The following is a description of a gene set: Genes down-regulated in SaOS-2 cells (osteosarcoma) upon knockdown of YY1 by RNAi. Human Gene Set: DE_YY1_TARGETS_DN species: Homo sapiens from publication de Nigris F, Rossiello R, Schiano C, Arra C, Williams-Ignarro S, Barbieri A, Lanza A, Balestrieri A, Giuliano MT, Ignarro LJ, Napoli C (PMID 18339860) We know that the Yin Yang 1 protein (YY1) overexpression is positively and strongly correlated with the degree of malignancy of bone tumors. Therefore, we questioned whether we could influence cell invasiveness by deleting YY1 in human osteosarcoma cells (SaOs-2), as tested in Matrigel-coated filters and metastasis implantation of such osteosarcoma cells in vivo, by serial analysis with nuclear magnetic resonance. Moreover, we focused our work on the chemokine receptor CXCR4 and its inhibition by T22 antibody, as well as on systemic (direct in vivo assay) and computer-assisted imaging of angiogenesis-related metastasis. Results showed that cell invasiveness and metastasis implantation by wild-type SaOs-2 cells, as evaluated by histology and immunohistochemistry, are associated with up-regulation of CXCR4 expression, which in turn was significantly reduced by T22. In addition, deletion of YY1 (siRNAYY1-SaOs-2) induced a significant decrease of cell invasion and metastasis growth. This phenomenon was associated with decreased vascular endothelial growth factor (VEGF)/angiogenesis and a complex rearrangement of the gene expression profile as evaluated by microarray analysis. In conclusion, YY1 and VEGF/CXCR4 seem to intervene in the pathogenesis of the malignant phenotype of osteosarcoma by acting on cell invasiveness and metastasis growth., and this is the list of marker genes: CD2AP, CYLD, INHBA, CDK1, HSP90B1, ENC1, CAPZA2, CDC27 (NCBI Gene Id 996), WDR1, SRSF9, RBL1, NBL1, TAGLN2, OSMR, PRKD3, EGFR, HIF1A, BARD1, ITGAV, PRKAA1, DNTTIP2, PAFAH1B1, STAG1, IFT57, PRKACB, HNRNPC, CCNG1, APC, USP16, ANGPT1, ITGA4, IL13, GSPT1, EPAS1, TGFB2 (transforming growth factor beta 2, NCBI Gene Id 7042), DST, PTP4A1, MACF1, CSNK1G3 (casein kinase 1 gamma 3), RBBP8, CCNE2, LPAR1, TACC1, TNFRSF11B, EGF, NUMA1, MET, ANXA1, EPHA3, PKN2, RB1, GDI2, NRP1, SOCS5, RASSF3, HIPK2, PNN, CLIC4, BTG4, FGF13, IPO7, SNX3, CCNL1, CALD1, NAA15, CASP8AP2, ERAP1, BDKRB2, PDHA1, CUL5, NCOR1, SEPTIN10, SMNDC1, TDRD3, ARIH1, PTEN, GNA13 (NCBI Gene Id 147219), RASA1, FN1, TUSC3, RAB6A, ECT2, AGGF1, ERBIN, RBBP6, TTK, USP9X, RGS17, FAS, MPHOSPH9, HNRNPH1, EPS8, RBL2